The following is a description of a gene set: Human Gene Set: HP_PALMOPLANTAR_CUTIS_LAXA Loose, wrinkled skin of hands and feet. Palmoplantar cutis laxa species: Homo sapiens, and this is the list of marker genes: FGFR2 (fibroblast growth factor receptor 2), ATP6V0A2, FGFR3, PLOD1, RIT1 (NCBI Gene Id 6016), ZNF469, C1R, MRAS, LZTR1